The following is a description of a gene set: Cytokines mediate cell-cell communication in the immune system and represent important therapeutic targets. A myriad of studies have highlighted their central role in immune function, yet we lack a global view of the cellular responses of each immune cell type to each cytokine. To address this gap, the authors created the Immune Dictionary, a compendium of single-cell transcriptomic profiles of more than 17 immune cell types in response to each of 86 cytokines (>1,400 cytokine-cell type combinations) in mouse lymph nodes in vivo. A cytokine-centric view of the dictionary revealed that most cytokines induce highly cell-type-specific responses. For example, the inflammatory cytokine interleukin-1β induces distinct gene programmes in almost every cell type. A cell-type-centric view of the dictionary identified more than 66 cytokine-driven cellular polarization states across immune cell types, including previously uncharacterized states such as an interleukin-18-induced polyfunctional natural killer cell state. from publication Cui A, Huang T, Li S, Ma A, Pérez JL, Sander C, Keskin DB, Wu CJ, Fraenkel E, Hacohen N (PMID 38057668) studied in species Mus musculus Mouse Gene Set: CUI_NK_CELL_IL1A_RESPONSE_DN Genes negatively differentially expressed in cell type: NK cell upon treatment with cytokine: IL-1α in mouse lymph nodes in vivo., and this is the list of marker genes: Ncr1, Cd48, Fosb, Tspan32, Btg2, Ms4a4b, Ppp1r18, Ahnak (AHNAK nucleoprotein), Fcer1g, Nkg7, Myo1f, Plekhj1, Dynll1, Ier5, Crip1, Ccl4, Klf2, Ptprcap, Hnrnpf, Hcst, Gem, Ndufb7, Calm2, Cd9, Cd52, Ctsw, Zfp36, Dnajb1, Cd160 (CD160 antigen), Tyrobp, Ctsd, Xcl1, Samd3, Ezr, Cd2, Fos, Hsd11b1 (hydroxysteroid 11-beta dehydrogenase 1), Jund, Srsf2, Cfl1, Ccl3, Lgals1, S100a6, Vim, Itgb7 (integrin beta 7), H2az1, Lck, Emp3, Arl4c, Zeb2, Atp5f1e, Jun, Efhd2